The following is a description of a gene set: species: Homo sapiens Rapid and unexpected death. Sudden death Human Gene Set: HP_SUDDEN_DEATH, and this is the list of marker genes: LRP6, CRLF1, MYBPC3, LDB3, TECRL, DSG2, CLIP2 (NCBI Gene Id 84805), RBM20, GPD1L, LDLR, RFC2, HRAS, ANK2, CACNA2D1, DPP6, SCN1A, IKZF1, GTF2IRD2, DNAJC19, BAZ1B, DTNA, FKBP6, CALM2, MYLK, SYNE1, HLA-DRB1, GTF2I, DSP (desmoplakin), WIPF1, NOS1AP, WWOX, TBX5, AKT1, DSC2, MYH6, ELN, HCN4, CSRP3, GNB2, SNTA1, TBL2, TPM1, JUP, NUP155, DNAJC30, TTN, SCN10A, UBR7, TNNI3, KCNE2, HLA-B, ABCG5, LIMK1, BUD23, PGM1, CLCF1, CPT1A, MYH7 (myosin heavy chain 7), SLC32A1, CALM3, PTPN22, HADHA, TNNT2, ACAD9, LEMD2, METTL27, ALG10B, NCF1, KCNJ5, ENPP1, STX1A, TBC1D24, TNNC1, TMEM43, TGFB3, KCNH2, MYLK2, ABCG8, FLNC, GNAI2, FHL1, SHQ1, FHOD3, MLXIPL, FIG4, EIF4H, PKP2, ACADVL (NCBI Gene Id 37), TMEM270, MYL2, TSPYL1, PCSK9, MYL3, MYOZ2, PPA2, TRDN, ABCA12, KCNQ1, ABCC6, SLC4A3, SCN8A, KCNE1, CAV3, CASQ2 (calsequestrin 2), DES, RYR2, LDLRAP1, SCN4B, WAS, EMD, APOB (NCBI Gene Id 338), SYNE2, P4HA2, CPLX1, PRKAG2, GUF1, CALM1, KCNJ2, SMAD3, SCN5A, SOST, CACNA1C, LMNA, AGK, SGCD, AKAP9, VPS37D, KLHL24, GTF2IRD1, EYA4